The following is a description of a gene set: Genes containing one or more binding sites for (AEBP2) in their promoter regions (TSS -1000,+100 bp) as identified by GTRD version 20.06 ChIP-seq harmonization. studied in species Homo sapiens from publication Yevshin I, Sharipov R, Kolmykov S, Kondrakhin Y, Kolpakov F (PMID 30445619) Human Gene Set: AEBP2_TARGET_GENES, and this is the list of marker genes: LINC02733, GBF1, SKA2, NR4A2 (NCBI Gene Id 4929), HYKK (NCBI Gene Id 123688), C15orf48, MRPL15, DPF2, MACO1, SNX8, POLR1A, TTC13, UBA1, IBTK, CFAP221, TULP3, IDH3A, PROSER1, SLC25A42, SEMA3C, ENSG00000275740, OXR1-AS1, ZFAND3, ENO3, FAM53C, USF3, IRGQ, MALINC1, CREB1, LINC02026, BMAL1, FBXO5 (F-box protein 5), TMCO1, ZC3HC1, RBM15-AS1, YIF1A, BBX, NOP2, ANP32A, GOLT1B (golgi transport 1B), MAT2B (NCBI Gene Id 27430), ZDHHC5, PDCD11, SRC, ZNF436, HNRNPH1, ASF1B, DDOST, ZNF524, RBM15, DPH3 (diphthamide biosynthesis 3), SKOR1-AS1, ZNF680, CDCA7L, KAT7, PAXIP1-AS2, MSL3, ZNF77, PRR14, S100A14, IQCD, SATB2, SLC25A25, DNMT1, PNKD, WTAP, PPM1L, ZNF436-AS1, ETV2, DDR1, PRR15, TTC9C (tetratricopeptide repeat domain 9C), STPG1, UBE2C, RMI2, FAM227A, MRPS24, DCUN1D3, ACTL6A, PFN2, RMND5A, TTF2 (transcription termination factor 2), TANK-AS1, TPD52, MRPL48, ATG101, ENSG00000267698, CEP131, LSR, RNF5, COPS5, SNHG10, HNRNPC, SAP30L-AS1, FOSL2, SIRT4, STRIP2, RAB28, UQCR10, PIF1, OXSR1, FAM110A (NCBI Gene Id 83541), DDX3X (DEAD-box helicase 3 X-linked), ACYP2, CADPS2, SPC25, PMF1 (NCBI Gene Id 94958), LRRC61, MYL12B, PHRF1, ATF7, MYL12-AS1, PDXDC1, THAP8, ZCWPW1, PURA, LNCTAM34A, AFMID, TCP11L2, TENM3, TOX4, GATAD2A, NR2F2, TRNAU1AP, UVRAG, RPL37, ZNF410, POLR1B, IGF2BP3, PLS1, GTF3C5, GIPC1, NAB1, PDE4D, TCF19, ZBTB4, ZNF721, FIZ1, EVI5L, PIP4K2B, IFIT3 (NCBI Gene Id 8376), GLRX5 (NCBI Gene Id 51218), SUCO, KCNAB2, ABLIM1, H4C8, SGK2, MAIP1, PKIA, RPL18, DDX49, PCLAF, ENSG00000239137, HDAC6, TCAIM, BCCIP, COX6B1, CYB5D2, TMEM150B, SNX1, PPP5D1P, CEP250, EIF4A1, GPATCH2, ZZEF1, CBR4, MAT2A, LIN37 (NCBI Gene Id 55957), HMGB1 (NCBI Gene Id 3146), MRPS27, FKBP3, VDR, SREK1IP1, SRI, KDM4A, ARMH4, RRBP1, SRSF1, PFDN4, ZNF785, ABHD16A, FRMD6, NKAPD1, CDC20, TSTD1, TEDC1, ASNS, MED24, CFAP418, LYRM1, HINFP, RAB2B, TMEM160, PUS1, GALT, KBTBD2, MIR4479, TSC22D1, TMBIM6, RBM27, ARRDC4, HGS, CCNB3, FAM219B, MAF1, RNASEK, DHCR24, PPM1L-DT (PPM1L divergent transcript), GSTO2, GABPA (GA binding protein transcription factor subunit alpha), ATP8A1, KIF1B, H2BC6-AS1, DIAPH1, ALDH4A1, GOLPH3L, RBM7, TYMS, PMEL, MCM7, NUBP2, TBC1D22A, NECTIN3-AS1, NOL6, SQSTM1, COG5, VARS1, PGP, RFWD3 (NCBI Gene Id 55159), LINC00881, CENPE, MIA2, USP5, SYS1, SELENOW (selenoprotein W), CYTH2, CDC40, CKAP5, BBLN, VASP, UCHL3, FRAT1, BABAM1, PRR15-DT, POLR1G, CHCT1, DNMBP, DGKA, NR2F1, PRKCE, KPNB1, BRD2, TOP2B, H3C6, ADAMTSL5, DNAJC28, MNT, EIF3B, ADGRV1, SPHK2, USP15, WEE2-AS1, DPH2, ZBTB26, CFAP20, RPS27, HOXD3, SNHG29, SMC1A, TYMSOS, C6orf62, CDCA3 (NCBI Gene Id 83461), ZCCHC10 (zinc finger CCHC-type containing 10), UQCRH, DCAF15, PDE6D, CAMTA1-DT, FKBP9, LARP4, LINC02918, CMC2 (NCBI Gene Id 56942), ZDHHC2, TRAF2, NABP1, RNU2-17P, GMDS, NFATC2IP, NACA, ATG16L2, PRDX2, CSPP1, NMD3, HSCB, PRADC1, ASAH1-AS1, DPAGT1, SARNP, ANKRA2, TRAPPC13, SNX3, BTN2A2, TUBB, SMC3, BOD1L1 (biorientation of chromosomes in cell division 1 like 1), GPR108, DOLPP1, HNRNPU, HYOU1, LMBR1, DCAF6, TTC41P, HSP90AA1, CCDC192, OS9, AMACR (NCBI Gene Id 23600), PUS1-AS1, CXCL2, CBY1, TYW5, PPP1R1B, SSBP1, ALKBH1, IMMP1LP1, RPS14, MPND, MRPL18, ALKBH6, NCOA2, CD164, CCND3, KMT5C, DECR1, RBBP5, HSP90AB1, ANKHD1, COX18, MYO9B, SCUBE2, RPL30, PQBP1, CDK2AP2, ZNF689, CCHCR1, MGRN1, MIR1289-1, CCDC77, KDM4B, FAM161A, GABARAPL1, PPFIA3, SIRT2, ARRDC3-AS1, SEC24A, CFAP298, TRIM9, LMAN2, ZNF92, ARHGAP19, RPL23AP95, CDC23, ADPRHL1, PYGO2, FSTL4, TNRC6B-DT, CNPY3, HDAC2-AS2, ZNF473, ZNF691, H3C12, H2BC15, PPWD1, TJP3, RMI1, NRSN2, TAF8 (NCBI Gene Id 135763), TMEM260 (transmembrane protein 260), LIPE, LINC-PINT, TAF15, RNF186, FOXP1, MTO1, EEF1A1, POLR2I, TCP1, KRT8, MAP3K13, C6orf226, RBCK1, POR, HMG20A, ZSWIM3, ZNF106 (zinc finger protein 106), MCEE, SLC17A5, KLF5, CWC27, SLC35E2B, FAM120AOS, AKR1E2, COQ8A, SPG7, P4HB, HERC3, EIF5 (NCBI Gene Id 1983), GNG12-AS1, FBRS, SLC26A2, LINC00963, ZDHHC7, KATNB1, PSMA3, FAM13A, EPB41L4A-AS1, TBC1D17, RPPH1 (NCBI Gene Id 85495), KPNA6, LRIF1, NGDN, ABCA7, TIMM8B, ZMYND8, MEPCE, SARS2, TSPYL1, CEP63, TARS2, SNORD42B, MALAT1, TMEM218, RBKS, ASAH1, C5orf22, C21orf91, MIR22HG, NIPSNAP2 (NCBI Gene Id 2631), CCDC124, RAB8A, RHCE, KANK3, PPT2-EGFL8, CCZ1P1, ANKZF1, ZNF12, RNFT1, DNAAF5, GSPT1, SLC16A5, CLDN7, ZNF774, H2BC13, SLC7A6, CARS2, KCTD9, SMIM7, RNU5B-1, BNIP1, TOP2A, KAT6B, STARD3NL, HAUS8, NIPAL3, HNRNPK, HJURP, PTPN23-DT, GPRC5A, TAFA2, AP5Z1, COPZ1, BAZ1B, TNIP1, FBXO33, ARPC4-TTLL3, AAMP, TDRKH-AS1, BCL2L1, PIERCE2, ZCCHC7, TDRKH, RMND5B, PCAT7, MTMR12, TENM3-AS1, ANKRD13A, KCNIP2-AS1, TBCB, LINC02038, COMMD6, SEL1L, AKR1D1, MOCS3, SPRY4, TRIP10, FRYL, RBM42, DRC3, MTOR, ING1, RBM22, CIC, RAB11A, KPNB1-DT, PTCD3, CCT5, VCP, CDON, CFAP298-TCP10L, POLR2A (RNA polymerase II subunit A), NDUFAF8, OXR1, RCCD1, GET3, CBR4-DT, FRAT2 (FRAT regulator of WNT signaling pathway 2), ATP8A1-DT, CCDC61, DMXL2, TMEM45A, ANAPC13, MLEC, ZNF267, MADD, CFAP43, TIMM17B, EED, ATP5MK, PLEKHG2, SERINC4, AQR, ACP6, ZNF207 (NCBI Gene Id 7756), JPT1, DGCR8, NXPE4, FAAP24, MTMR4, IPO13, MPV17L2, NCDN, OGDH, CAND1, DHX38, CCNB1, RNASEK-C17orf49, HMGN4, MICOS10, AKIRIN1 (NCBI Gene Id 79647), RNU6-841P, FAM168A, IFIH1, BCAS3, HNRNPUL2, H2AC4, BZW1, AHRR, SMARCAL1-AS1, CEP89, CALR, ZNF526, ANXA4, RPLP1, SERINC5, UBE2S, PCBP1, PCGF3-AS1, SERPINB6, ALDH6A1, TM9SF4, RGMB-AS1 (NCBI Gene Id 503569), EXOC4, UBALD2, CDIPTOSP, NHP2, TRMT44, PDXP-DT, ATP5MC1, BNIP2, DUT, SHROOM3, HOXC6, ANP32E, FEZ2, ABHD12B, ST7L, UIMC1, CYB5B, AVL9, RTRAF, RBM39, RNU6-1301P, CDC42EP4, AKT1S1, MAOA, COQ7, ARID4A, MINDY2, FAM174B, NLK, LAPTM4A-DT, MSH3, RALY, GCA, BZW2, IL23A, TRIM33, TARDBP, CHEK2, HNRNPL, OXNAD1, SPATA17, CNOT10, NUMB, TMEM69, DHX57, DUT-AS1, MOSPD3, SPC24, ZWINT, TBC1D10B, CD101-AS1, ANKHD1-DT, H2AZ2-DT, TLL2, PHF14, LINC02651, TMEM38A, SPSB3, PARK7, DAP3, RFX1, MAGI3, ZNF767P, PHTF2, DPM1, PURB, COQ5, MORN2, ZNF273, TK1, EML6, TANGO2, EEF1D, LINC02926, UBA52, DHCR24-DT, CEP152, HOXB6, PPIA, DHFR, PRMT1, TOM1L2, CHD1, MTMR14, RAB11B-AS1, RNF181, CASC11, H2AC15, ZBTB5, CNEP1R1, HOXA3, UFSP2, WDR5B, HNRNPUL1, YJU2, SLC25A28-DT, CEP164, FLAD1, STX5-DT, NEMP1, NR6A1, PBX1, PICK1, RPS6, RPL22, HYCC1, ZNF574 (zinc finger protein 574), LIMA1, ASH1L, CDKL3, AP3M2, LSM3, PTDSS1, DANCR, TMC4, PWWP2A, AKAP8L, UTP18, LIN54, GRPEL2-AS1, SUMF2, RGMB, HSF2, GRPEL2, CDC25C, PLEKHG5, OTUB2, CEP57, FDFT1, ZNF555, SNORA13, ARMH1, GBA1, RPS19, CHCHD6, LINC01852, UBE2D3, NME2, VPS35, SPRED2, SP2, RECQL, ZSWIM4, HYAL3, SREK1, ATF6, AATF, SIGMAR1, TMEM202-AS1, NR2F2-AS1, DCAF11, DCAKD, WDR45, NOCT, RBM47, HMGN1P16, ZNF687-AS1, EHMT2, KLF3-AS1, PDXP, CKS1B (NCBI Gene Id 88475), HDAC2, TRAF6, CNOT1, KIAA0319L, HEXA-AS1, SEMA4B, CSNK2A1, GSK3B, AP4M1, MTERF3, LIPE-AS1, TPX2, TIGD5, ANKRD17 (NCBI Gene Id 84177), PSMC3IP, FAM169A-AS1, TRA2B, TBC1D1, OGFOD2, WDCP, KHSRP, UBP1, RNF13, ANKRD11, HMGCS1, STT3A (STT3 oligosaccharyltransferase complex catalytic subunit A), ISL2, MTFR2, RUFY1, UNG (uracil DNA glycosylase), ATPSCKMT, LINC02313 (NCBI Gene Id 105370439), MALSU1, ARL16 (NCBI Gene Id 339231), MSANTD4, ULK4, TXNIP, SCAF1, PROSER3, SNORD59A, CEACAM1, CLRN3, NFX1, ANKHD1-EIF4EBP3, MBNL1, SH3RF2, FHIT, PRKDC, SAP30L, KLHDC10, JAG1, ENSG00000261335, ANKMY2, NFKBIB, LIN52, RMDN3, CENPN, DISP3, LINC00649, ZNF789, WASF1 (NCBI Gene Id 8936), ZNF629, CENPK, RIBC1, HBP1, SLC7A11, GPBP1L1, COQ7-DT, GRHL2-DT, ZNF219, COPS7B, MED19, SNAI3-AS1, TTLL7, FDPS, ALDH2, TRAFD1, ELOB, PHPT1, ARMC1, DPP9, CFAP96, CENPM, PYGO2-AS1, H2AX, BRAT1, HAT1, SNORD49B, PARP2, AP2A1, GATAD2B, UBE2B (NCBI Gene Id 7320), DOHH, METTL17, STK35, RAB11B, MCM3, C17orf75, ZFAND6, SLBP, ABCA11P, THAP6, MROH8, PXN-AS1, PRR11, PRKCE-AS1, ARIH1, MFSD6, PKNOX1, ECE1, ZNF691-DT, LRRC31, H2AJ, NMT1, DNAJC7, JUP, ERCC6L2-AS1 (ERCC6L2 antisense RNA 1), RPL23A, KDM3A, MVP, AFF1, OGA, MEAF6, SHC1, TNFSF9, CDK16, POLR1D, AKAP9, ISY1-RAB43, RHBDD3, RPLP0, MIR9-2HG, DNAAF3, EIF2AK3-DT, TNRC6B, EPS8, MVD (NCBI Gene Id 4597), CPSF2, RHOQ, DRAM1, SCAI, LRPPRC, ATF7-NPFF, MBTD1, GOLM2, NRL, TMX2 (NCBI Gene Id 51075), PDE7B-AS1, TTBK2 (tau tubulin kinase 2), AHCYL2, CENPF, VPS37C, SART3, PNN, INPP5B, DGAT2-DT, INAVA (NCBI Gene Id 91162), DNAJB5, FLCN, SNORD35B, NRSN2-AS1, USP3, NDUFB1, NAIF1 (NCBI Gene Id 203245), MRPL46, PTGES3, ARRDC3, PLPBP, MRPL36, FAM76B, VPS28, ZNF678, ELP4, PPT2, LANCL2, RNF34, PTRH1, C21orf58, POC5, TEPSIN, CALM3, TPCN1, CREB3L2, FAM156A, ZNF564, PRKCI, DOK4, NPDC1, TRAF7, UEVLD (NCBI Gene Id 55293), HDGFL2, CHMP3, TMPO, HYAL2, CDK1, GSK3B-DT, SECISBP2L, LSG1, PABPN1, DDX6, RPL7L1, MSMO1, PEAK1, ARHGAP19-SLIT1, WASF2, INKA2 (NCBI Gene Id 55924), RHOBTB3, NOP16 (NCBI Gene Id 51641), CENPA, MYL12A, PSMA3-AS1, OXA1L, UROS, ULK3, TMEM60, H2AZ2, XRCC3, PRELID2, NFE2L1-DT, RIOK2, MIR4999, TMA7, ENSG00000263080, PRKACA, MYC, TMPOP2, ANAPC7, ZNF823, MIA2-AS1, ATG9A, SYVN1, SLC25A28, EWSR1, DNAJB12, PLA2G2A, ZNF576, OSBP, ADGRL1-AS1, RPL18A, PDK2, ILF3, ANAPC5, CDCA2, EDEM1, SPRYD3, CA11, PPFIBP1, TRIM23, ARID1A, DCAF7, ERI3, TMEM161A, NOL8, PIK3R3, ARG2, ERI2, KIF16B, POLG-DT, ORC6, PYGB, OGT (NCBI Gene Id 8473), RPRD1B, DUS4L, NAA80, PHLDB2, FRMD5, CEP41, DNAJC27-AS1, JMY, TCTN3, CUL2, DDIAS, PIH1D2 (PIH1 domain containing 2), GLRX, MYL11, PTOV1, NECTIN3, TPBG, DPF3, ZNF414, VPS41, AGPAT1, PGRMC2, ZNF431, AGFG2, TANK, TRIM68, ZFYVE21, TMEM62, GRIPAP1, LENG1, XPO1, HDAC1, H2AC12, MEIS1, NDUFB2, PAN2, FAM117A, PMF1-BGLAP, ACYP1, AMBRA1, ISCU, RAB3A, LINC02924, ACBD5, DNM2, PPP1R13L, EFNA1, MICOS10-NBL1, RND1, TUBB4B, MIR638, MRPS11, SETD9, GLCCI1, ALDH1A2 (aldehyde dehydrogenase 1 family member A2), SOCS5, FIS1, TXNL4B, INKA2-AS1, TIMM44, RAD51B, PSIP1 (PC4 and SRSF1 interacting protein 1, NCBI Gene Id 93428), ORMDL2, BET1L, DNAJB5-DT, PDXDC2P-NPIPB14P, ZBTB3, PAIP2B, SHARPIN, LINC02320, DDA1, MICAL3, HIBCH, IMMP1L, ABHD11, STARD7, SERF2, ZFAND3-DT, CTTNBP2NL, RRAS, TRIM7-AS2, TTC16, DCAF17, IFT27, CREBRF, TMEM94, PCYOX1L, HSPB6, ISY1, UQCRC2, SMARCAL1, RBBP6, DNAJA3, RIC8A, HDAC5 (histone deacetylase 5), SYS1-DBNDD2, GGCT, ARVCF, LRP4-AS1, BCL6, ANAPC15, LINC01342, TMEM39A, SNORA26, POLG, SHKBP1, FUS, DROSHA, MCM4, PDXDC2P, RAG1, BATF2, EML2, FOS, EIF2AK3, NFE2L1, WBP1, SRRM5, ERCC6L2, PCBP1-AS1, POLR3A, YY1AP1, CDIPT, WDR62, ABHD2, GARS1-DT, DEDD2, CAMTA1, ABCB9, GPR160, DSE, ARPC4, HSPA8 (NCBI Gene Id 3312), SFXN5, NHLRC3, RPS12, DGAT2, MAEA, VPS72, SASH1, IGFL4, FAM43A, RN7SKP119, MPZL1, SYPL1P2, TADA3, DDX21, RAB5B, ALKBH7, PPP2R5A, METTL13, CHD6, TMEM219, SPAG7, GPT2, GALK2, CENPP, RNFT1-DT, PRRT1, DCTN4, PER2, BRIP1, LINC02960, ZNF695, RSL24D1, PGGT1B, WRAP53 (WD repeat containing antisense to TP53), PCNT, HSP90B1, UBXN8, METTL8, KLHL20, TTC7A, MORN4, RPL19 (NCBI Gene Id 6143), SYNCRIP, ZSCAN20, SS18, RUVBL1 (NCBI Gene Id 8607), H2AC13, HNRNPUL2-BSCL2, HEXA, LSM4, EIF3F, ZNF687, PRCP, CSNK1G3, ZNF354B, NPHP4, ZKSCAN5, STX10, ZBTB20, GNB2, COL6A2, LRRC41, RPN2, STXBP5-AS1, RHBDD1, STAP2, ATP6V1E2, ACTR3C, HIGD2A, VRK3, MEGF11, ACTR2, ACOT8, CIAO2A, ATP5F1B, ZC2HC1C, HELQ, ENSG00000234162, IFT52 (NCBI Gene Id 51098), TICRR, TMEM53, HSPA1B, NEDD4L, CCT7, FUT8, COPE, C1QTNF6, CPEB4, STK11IP, DYRK1A, ZNF815P, AP1G1, WHAMM, TTLL5, BLOC1S6, PAFAH1B3, SPAG5, HHAT, TSEN15, VDAC1